Given this list of marker genes HOXD13, RAB23, GLI3, CPLX1, IFT172, RAB34, NEK1, NSD2, ZSWIM6, FGFRL1, PITX1, SMO, CTBP1, FGFR2, LETM1, MEGF8, CPLANE1 (ciliogenesis and planar polarity effector complex subunit 1), LMBR1, KIF7, here is a description of the gene set: Preaxial foot polydactyly Human Gene Set: HP_PREAXIAL_FOOT_POLYDACTYLY species: Homo sapiens Duplication of all or part of the first ray.